Given this list of marker genes Tnf, Mbp, Tlr4, Postn (NCBI Gene Id 99708), Tgfb1, Tirap, Lrp1, Mif, Hmgb1, Ccl5, Cd74, Defb25, Ccn1, Lpl, Mcoln2, here is a description of the gene set: studied in species Mus musculus Any process that activates or increases the frequency, rate or extent of chemokine (C-X-C motif) ligand 2 production. Mouse Gene Set: GOBP_POSITIVE_REGULATION_OF_CHEMOKINE_C_X_C_MOTIF_LIGAND_2_PRODUCTION